The following is a description of a gene set: Genes up-regulated in Foxp3-Fusion-GFP T reg (FOXP3+): B6 versus NOD background. The aim of this study was to quantify the impact of chimeric Foxp3-GFP protein on the Treg cell transcriptional program. from publication Darce J, Rudra D, Li L, Nishio J, Cipolletta D, Rudensky AY, Mathis D, Benoist C (PMID 22579475) Human Gene Set: GSE37605_C57BL6_VS_NOD_FOXP3_FUSION_GFP_TREG_UP studied in species Homo sapiens, and this is the list of marker genes: IL9, KCNC2, RNASE13, CNBD1, STRA8, PKDREJ, KRT86, ADCY1, ANXA10, FEM1A, ADCYAP1, DKK1, GLDC, FGA, ITIH4 (NCBI Gene Id 3701), CRYGS, CFAP184, HOXD13, CFAP206, DFFA, SMOC1, HRH3, EVC2, LRRC26, PSD, HSD17B13, IRS4, MEPE, KLHL35 (NCBI Gene Id 283212), SSMEM1, LRRC51, MMP21 (matrix metallopeptidase 21), SHC4, DIPK2B, RGS17, C1QL4, PTK7, CDKN2A, LRFN5, PKD1L2, SLC46A2, MIR27A, SLC25A34, GRIN3A, XRCC3, ECT2L, HOXB6, SRSF8, IL22RA2, ANKRD24, C20orf141, BPIFB9P, LUZP2, EYA4, NMS, DYTN, H3-3B, TYR, PPL, FOXF2, NEFM, FGF6, NHLRC4, IL4, CPLX1 (NCBI Gene Id 10815), RPLP0, ADGRF1, COL8A2, GPR37L1, FZD2, MUSK, KRT36, SEMA4G (semaphorin 4G), C1orf105, MYOD1, GPR161, CPN1, C1orf216, HHIPL1, AK4, CACNB4 (NCBI Gene Id 785), LMOD1, CRYBG2, IL20, KDM8, CTU1, SPMIP2, SEMA4B, CIMIP1, MFSD4B, IL17A, RAB25, GJA4, ZIC4, ADRB3, TNFAIP8L3, ANKFN1, ASB15, MIR378A, SPAG11A, COL10A1, MTNR1B, GRIA1, SPATA31D1, PLIN1, GIPC3, KIAA1671, JPH1, EFR3B, SLC35F1 (solute carrier family 35 member F1), KLK9 (NCBI Gene Id 284366), TRIML1, SLC16A8, TEX22, OLR1, ACR, SIX3, CSMD2, MORN1, ST8SIA5, HTRA4, SCGB3A1 (secretoglobin family 3A member 1), ARMC12